Given this list of marker genes TBX15, GPC4, MYL2, GPC3, VAMP1, SELENON, SNAP25, SLC5A7, KIF22, MKKS, AHDC1, CLCN3, IARS2, YWHAE, UBE3B, ALDH18A1, ATP6V0A2, PYCR1, PPP2R5D, TPM3, CHRM3, LONP1, CHAT, FIG4, SYT2, PLOD1, NGLY1, DNAJC21, HACD1, TBCD, ABCC9, RECQL4, MYO9A, KDM6A, TPM2, COL12A1, BICD2, SNRPB (small nuclear ribonucleoprotein polypeptides B and B1), THRA, PTRH2, ECEL1, WNT7A, KAT6B, SIX1, OBSL1, LRP1, NSDHL, PUF60, SHROOM4, COL3A1, FHL1, EYA1, FLNA, ATP6V1E1, ZIC3, PIEZO2, CCDC8, AGRN, COL1A1, GEMIN4, MAP3K20, SLC25A1, PAFAH1B1, ITGA7, CLTCL1, HDAC4, KMT2D, ACTA1 (actin alpha 1, skeletal muscle), CUL7, USP9X, HSPG2, ZNF469, MAP3K7, NAA10, RYR1, DHODH, TELO2, ATP6V1A, COL6A3, COL5A2, COL13A1, PORCN, COL6A1, SLC18A3, FBLN1, here is a description of the gene set: Congenital hip dislocation Human Gene Set: HP_CONGENITAL_HIP_DISLOCATION species: Homo sapiens